Given this list of marker genes PCGF2 (NCBI Gene Id 7703), SMARCA4, TAF4, ARID1B, COL11A2, SMARCA2, here is a description of the gene set: species: Homo sapiens Human Gene Set: HP_PROMINENT_INTERPHALANGEAL_JOINTS Prominent interphalangeal joints